The following is a description of a gene set: studied in species Mus musculus Mouse Gene Set: GOBP_REPRODUCTIVE_BEHAVIOR The specific behavior of an organism that is associated with reproduction., and this is the list of marker genes: Ncoa2, Grn, Grin1, Pten, Ncoa1, Th, Oxt, App, Drd4, Mapk8ip2, Ddo, Prl, Tgm4, P2ry1, Brinp1, Hdac4, Dmrta1, Crebrf, Oprm1 (NCBI Gene Id 18390), Dbh, Kalrn, Avp, Ednrb, Ada, Thrb, Fuom, P2ry2, Gabrb3, Fev, Cyp11a1, Klk14, Gal, Vmn2r116 (vomeronasal 2, receptor 116), Hcn1 (hyperpolarization activated cyclic nucleotide gated potassium channel 1), Thra, Hdac2, Taar5, Oxtr, Mbd2, Slc6a4, Esp1, Ppp1r1b, Acvr2a, Oprk1, Hexb, Trpc2, Ar, Avpr1a, Tacr1, Npas3, Pgr, Ppp1r9b, Nlgn4l, Cnr1, Vip, Serpine2, Gnaq, Shh, Drd1, Aplp2, Drd5, P2rx1, Esp22, Nhlh2, Abat, Ube2q1, Svs3a, Nr3c1, Npas1, Zfx